Given this list of marker genes Ism1, Osbp, Ccdc126, Zfyve16, Sfpq, Sgcd, Fhip2a, Oga, Ino80d, Ptpn6, Zswim6, Iqsec1 (NCBI Gene Id 79407), Fnip1, Yme1l1, Hipk3, Rftn2, Sort1, Bach2, Bcl6, Mms22l, Fermt2, Ube2b, Inpp5b, Gabpb1, Ubr1, Prickle1, Dgkd, Zc2hc1a, Dnajc30, Ppfia2, Insm1, Tle4, Pcdhb9, Slc4a7, Tram1, Dcun1d4, Kmt2e, Lhx2, Mosmo (NCBI Gene Id 233812), Fbxo34, Vcam1, Frmpd4, Orai3, Nxt2, Cttnbp2nl, Dynlrb2, Rabgap1l, Mecp2, Ddx21, Klhl15, Lrp6, Tmem255a, Tgfbr3, Atp8b2, Rab11fip3, Prr12, Bdp1, Zic1, Nckap1, Sall1, Dock3, Dcaf7, Fli1, Trappc13, Cbx3, Dlx5, Rictor, Rab2a, Mef2d, Slc15a5, Cilk1, Trp53inp1, Rab27a, Plekhg1, Hnrnpdl, Map2, Pcdh17, Arid4b, Tcerg1l, Soat1, Rgs4, Timp3, Tmtc4, Kmt2c, Zbtb5, Rev3l, Fgd4, Garem1 (NCBI Gene Id 97932), Ube3c, Yy1, Hoxc6, Plch1, Miga1, Stxbp1, Trio, Cdc42se2, Lrrcc1, Kmt2d, Stard13, Prrg3, Sh3gl3, Hhip, Bltp1, Scfd1, Smurf2, Bmp7, Myt1l, Cc2d2a, Gcc2, Tnfrsf11b, Rarb, Zmynd8, Slc30a5, Met, Ebf3, Sox9, Hycc2, Scrn3, Spag9, 1600012H06Rik (NCBI Gene Id 67912), Vkorc1l1, Strn4, Irx1, Nasp, Tcf7l2, Tamalin, Sp9, Cyp1a1, Diaph2, Gabra1 (gamma-aminobutyric acid type A receptor subunit alpha 1), Mon2, Myo9a, Naa15, Fbxo45, Pcm1, Epn2, Gria3, Golph3l (NCBI Gene Id 99919), Pafah1b1, Znrf3, Bmpr2, Kdm6a, Drg1, Hoxa10, Cds2, Ppt1, Set, Frrs1l, Kif3a, Mapk1, Tspan12, Ercc3, Crispld1, Zfx, Lrp1b, Tbx22, Ppp4r2, Scn2a, Irf2bp2 (NCBI Gene Id 672960), Nipal1, Mpz (myelin protein zero), Phf12, Magoh, Ralgds, Cert1, Hectd2, Lsm14a, Npy1r, Efna1, Arap2, Hsf3, Smim8, Osbpl3, Ppp2cb, Mcu, Mtor, Mllt10, Dnajb6, Pak2, Adss2 (adenylosuccinate synthase 2), Tenm3, Mbnl2, Meox2, Gsdma, Usp32, Dnali1, Mbnl3, Pou4f2, Rab18, Ikzf2, Asxl1, U2surp, Trip12, Rbm27 (NCBI Gene Id 225432), Calu, Spock3, Sash1, Slc8a1, Fgf7, Mob4, Cfl2, Aak1, Cav2, Samd4, Ark2n, Dennd6a, Foxf1, Rab11fip2, Snx3, Atrx, Rin2, Herc1, G2e3, Tnfaip8, Pdcd10, Cwc22, Acvr1c, Olfml2b, Rtn1 (reticulon 1), Sec11c (SEC11 homolog C, signal peptidase complex subunit), Ppp1r2, Rad51ap2, Robo2, Eea1, Csnk1g3 (NCBI Gene Id 70425), Fndc3b, Pcsk2, Hoxa9 (homeobox A9), Sun1, Usp42, Rbpms, Septin9, Smo, Cbfa2t2, Cd2ap, Clip1, Cnr1, Appl1, Arap1, Erf, Creb5, Usp25, Sncaip, Zik1, Irx5, Cdip1, Asap2, Ssb, Tmem154, Khdrbs3, Zfp280d, Dock11 (dedicator of cytokinesis 11), Tob1, Plpp3, Pum2, Prkaa1 (protein kinase, AMP-activated, alpha 1 catalytic subunit), Ripk2, Golim4, Vcl, Gata3, Casp8ap2, Rras, Btbd3, Tle1, Txlng, Xiap, Rab10, Vsig1, Otud1, Dagla, Klhl28, Mycbp2, Tcf24, Epb41l5, Zmym6, Iqgap2, Prdm16 (PR domain containing 16), Rasef, Art3, 4930579G24Rik, Dnajb4, Tgfb2, Tasp1, Btaf1, Ctla4, Lemd3, Sall3, Aifm1, Letm2, Hmgxb4, Plxnc1, Satb1, Chmp1b (charged multivesicular body protein 1B), Lrrc63, Gpcpd1, Edn2, Usp53, Hip1, Erbin, Akap6, Or4n5, Spin1, Ppp1r1c, Azi2, Cflar, Trappc10, Ube2o, Nrip1, Plekhm3, Mapk8, here is a description of the gene set: from publication Chen Y, Wang X (PMID 31504780) Genes predicted to be targets of miRBase v22 microRNA mmu_let_7f_2_3p in miRDB v6.0 with MirTarget v4 prediction scores > 80 (high confidence targets). species: Mus musculus Mouse Gene Set: LET_7F_2_3P